Given this list of marker genes DDR2, PTPN6, ZNF341, PSTPIP1, MEFV, here is a description of the gene set: Sterile abscess An abscess not caused by infection with pyogenic bacteria. Operationally, a sterile abscess is inferred if investigations of an abscess fail to reveal evidence of pathogenic organisms. Human Gene Set: HP_STERILE_ABSCESS studied in species Homo sapiens